Given this list of marker genes Irf7, here is a description of the gene set: studied in species Mus musculus Reactome Pathway: TRAF6 mediated IRF7 activation in TLR7/8 or 9 signaling part of: MyD88 dependent cascade initiated on endosome electronically inferred by orthology from the curated human pathway This event has been computationally inferred from an event that has been demonstrated in another species.<p>The inference is based on the homology mapping from PANTHER. Briefly, reactions for which all involved PhysicalEntities (in input, output and catalyst) have a mapped orthologue/paralogue (for complexes at least 75% of components must have a mapping) are inferred to the other species.